The following is a description of a gene set: Human Gene Set: GOBP_NEGATIVE_REGULATION_OF_ANTIGEN_PROCESSING_AND_PRESENTATION Any process that stops, prevents, or reduces the frequency, rate, or extent of antigen processing and presentation. species: Homo sapiens, and this is the list of marker genes: LILRB2, HLA-DOB, TAPBPL, THBS1, FGL2, HFE, FCGR2B, HLA-DOA, CD68 (NCBI Gene Id 968)